The following is a description of a gene set: Mouse Gene Set: GOCC_SPERM_HEAD_TAIL_COUPLING_APPARATUS A centrosome-based structure consisting of two cylindrical microtubule-based centrioles and associated components which anchors the flagellum to the sperm head. species: Mus musculus, and this is the list of marker genes: Prkar1a (NCBI Gene Id 80472), Cntln, Dnajb13, Glipr1l1, Ccdc159, Spata6, Akap4, Spatc1l, Ift88, Capzb (capping actin protein of muscle Z-line subunit beta), Cep131, Sun5, Fsip2 (fibrous sheath-interacting protein 2), Cep128, Pmfbp1 (NCBI Gene Id 67322), Spata6l, Ccdc42, Cfap47